Given this list of marker genes Plxna4, Mycbp2, Sema3f, Plxna3, Sema3a, Nrp1, here is a description of the gene set: The process in which a branchiomotor neuron growth cone is directed to a specific target site. Branchiomotor neurons are located in the hindbrain and innervate branchial arch-derived muscles that control jaw movements, facial expression, the larynx, and the pharynx. species: Mus musculus Mouse Gene Set: GOBP_BRANCHIOMOTOR_NEURON_AXON_GUIDANCE